Given this list of marker genes TMEM158, ANK1, SELENBP1, TSPAN5, TRAK2 (NCBI Gene Id 66008, trafficking kinesin protein 2), RHCE, PBX1, DCAF11, GYPA, FECH, MXI1, OPTN, BCAM (basal cell adhesion molecule (Lutheran blood group)), FAXDC2, GYPB, CDH1, OSBP2, TAL1, TNS1, SNCA, MOSPD1, CDC42BPA (CDC42 binding protein kinase alpha), ARHGEF12, SLC6A8, ABCG2, here is a description of the gene set: Top genes from cluster 8 of aculte myeloid leukemia (AML) expression profile; 69% of the samples are FAB M2 subtype. BACKGROUND: In patients with acute myeloid leukemia (AML) a combination of methods must be used to classify the disease, make therapeutic decisions, and determine the prognosis. However, this combined approach provides correct therapeutic and prognostic information in only 50 percent of cases. METHODS: We determined the gene-expression profiles in samples of peripheral blood or bone marrow from 285 patients with AML using Affymetrix U133A GeneChips containing approximately 13,000 unique genes or expression-signature tags. Data analyses were carried out with Omniviz, significance analysis of microarrays, and prediction analysis of microarrays software. Statistical analyses were performed to determine the prognostic significance of cases of AML with specific molecular signatures. RESULTS: Unsupervised cluster analyses identified 16 groups of patients with AML on the basis of molecular signatures. We identified the genes that defined these clusters and determined the minimal numbers of genes needed to identify prognostically important clusters with a high degree of accuracy. The clustering was driven by the presence of chromosomal lesions (e.g., t(8;21), t(15;17), and inv(16)), particular genetic mutations (CEBPA), and abnormal oncogene expression (EVI1). We identified several novel clusters, some consisting of specimens with normal karyotypes. A unique cluster with a distinctive gene-expression signature included cases of AML with a poor treatment outcome. CONCLUSIONS: Gene-expression profiling allows a comprehensive classification of AML that includes previously identified genetically defined subgroups and a novel cluster with an adverse prognosis. Human Gene Set: VALK_AML_CLUSTER_8 studied in species Homo sapiens from publication Valk PJ, Verhaak RG, Beijen MA, Erpelinck CA, Barjesteh van Waalwijk van Doorn-Khosrovani S, Boer JM, Beverloo HB, Moorhouse MJ, van der Spek PJ, Löwenberg B, Delwel R (PMID 15084694)